Given this list of marker genes Eif2s3x, Rpl13a, Eif3e, Eif3i, Eif2s3y, Impact (NCBI Gene Id 319442), Eif4h, Eif3m, Eif3j2, Eif4b, Nck1 (non-catalytic region of tyrosine kinase adaptor protein 1), Eif2b5, Eif3k, Eif2ak4, Ythdf2, Eif3h, Eif3a, Ncbp2, Mcts1, Eif3c, Pkp1, Eif3b, Eif3j1, Eif3l, Eif2s2, Eif2b1, Eif2d, Eif4ebp1, Eif3d, Mif4gd, Akt2, Mettl3, Dhx29, Slbp, Rbm4, Sh3bgrl, Eif2b4, Ncbp1, Eif4a1, Denr, Eif2b3, Eif2b2, Mcts2, Eif3g, Eif3f, Eif5 (eukaryotic translation initiation factor 5), Eif4a2, here is a description of the gene set: The process preceding formation of the peptide bond between the first two amino acids of a protein in the cytoplasm. This includes the formation of a complex of the ribosome, mRNA or circRNA, and an initiation complex that contains the first aminoacyl-tRNA. species: Mus musculus Mouse Gene Set: GOBP_CYTOPLASMIC_TRANSLATIONAL_INITIATION